Given this list of marker genes OPN1MW, RBP4, RDH12, RDH5, RLBP1, RBP1, OPN1LW, ABCA4, TTR, LRAT, STRA6, NAPEPLD, OPN1SW, here is a description of the gene set: Reactome Pathway: Retinoid cycle disease events The gene defects which cause diseases related to the retinoid cycle are described here. species: Homo sapiens part of: Diseases associated with visual transduction